The following is a description of a gene set: A process that is carried out at the cellular level and in which the structure of a lamellipodium is organized. Mouse Gene Set: GOBP_LAMELLIPODIUM_MORPHOGENESIS studied in species Mus musculus, and this is the list of marker genes: Abi1, Pdpn, Rreb1, Arpin, Wasf1, Snx1, Snx2, Myo9b, Coro1b, Wasf2, Enpp2, Cd44, Vil1, Coro1c, Plekho1, Kank1, Src